The following is a description of a gene set: Regulation of gene expression in beta cells species: Homo sapiens Human Gene Set: REACTOME_REGULATION_OF_GENE_EXPRESSION_IN_BETA_CELLS, and this is the list of marker genes: AKT2, FOXA3, SLC2A2, PAX6, NKX6-1 (NCBI Gene Id 4825), IAPP, INS, NKX2-2, AKT1, HNF4G, HNF1A (NCBI Gene Id 6927), FOXA2, PDX1, NEUROD1, PKLR, GCK, AKT3, MAFA, FOXO1, HNF4A, RFX6